The following is a description of a gene set: from publication Schaeffer EM, Marchionni L, Huang Z, Simons B, Blackman A, Yu W, Parmigiani G, Berman DM (PMID 18794802) Predicted targets of SOX9 that are down-regulated during early prostate development. Cancer cells differentiate along specific lineages that largely determine their clinical and biologic behavior. Distinct cancer phenotypes from different cells and organs likely result from unique gene expression repertoires established in the embryo and maintained after malignant transformation. We used comprehensive gene expression analysis to examine this concept in the prostate, an organ with a tractable developmental program and a high propensity for cancer. We focused on gene expression in the murine prostate rudiment at three time points during the first 48 h of exposure to androgen, which initiates proliferation and invasion of prostate epithelial buds into surrounding urogenital sinus mesenchyme. Here, we show that androgen exposure regulates genes previously implicated in prostate carcinogenesis comprising pathways for the phosphatase and tensin homolog (PTEN), fibroblast growth factor (FGF)/mitogen-activated protein kinase (MAPK), and Wnt signaling along with cellular programs regulating such 'hallmarks' of cancer as angiogenesis, apoptosis, migration and proliferation. We found statistically significant evidence for novel androgen-induced gene regulation events that establish and/or maintain prostate cell fate. These include modulation of gene expression through microRNAs, expression of specific transcription factors, and regulation of their predicted targets. By querying public gene expression databases from other tissues, we found that rather than generally characterizing androgen exposure or epithelial budding, the early prostate development program more closely resembles the program for human prostate cancer. Most importantly, early androgen-regulated genes and functional themes associated with prostate development were highly enriched in contrasts between increasingly lethal forms of prostate cancer, confirming a 'reactivation' of embryonic pathways for proliferation and invasion in prostate cancer progression. Among the genes with the most significant links to the development and cancer, we highlight coordinate induction of the transcription factor Sox9 and suppression of the proapoptotic phospholipid-binding protein Annexin A1 that link early prostate development to early prostate carcinogenesis. These results credential early prostate development as a reliable and valid model system for the investigation of genes and pathways that drive prostate cancer. species: Mus musculus Mouse Gene Set: SCHAEFFER_SOX9_TARGETS_IN_PROSTATE_DEVELOPMENT_DN, and this is the list of marker genes: Ywhaz, Ets1, Ankrd11, Sfrp1, Hoxa10, Cdk2, Ddx6, Klf3, Zfp521, Hmgb1, Tcf4, Meis1, Nasp, Elavl4, Fbln5, Stmn1, Trim8, Dab2ip, Elavl1, Pum1, Tiam1, Basp1, Mycl (NCBI Gene Id 16918), Nav1, Rassf2, Pcdh18, Sptbn1, Cdc27, Crmp1, Inhba, Nfix, Syt4, Phf6, Igf1, Smarca5, Cdca7, Slitrk1, Colec10, Rrm2, Eif3a, Slit2, Rbfox2, Nudt3, Olfm1 (NCBI Gene Id 99427), Sox4